Given this list of marker genes Exosc10, Ctc1 (CTS telomere maintenance complex component 1), Tnks2, Pot1b, Slx4, Trp53 (transformation related protein 53), Pml, Mcrs1, Hnrnpc, Tinf2, Ercc4, Terf1, Parp1, Gnl3l, Tnks, Pot1a, Stn1, Nat10, Pif1, Dcp2, Tent4b, Src, Pinx1, Acd, Terf2, Hnrnpu, Ten1, here is a description of the gene set: Mouse Gene Set: GOBP_NEGATIVE_REGULATION_OF_TELOMERE_MAINTENANCE_VIA_TELOMERE_LENGTHENING Any process that stops, prevents or reduces the frequency, rate or extent of telomere maintenance via telomere lengthening. species: Mus musculus